The following is a description of a gene set: studied in species Mus musculus Mouse Gene Set: GOBP_REGULATION_OF_LIPID_KINASE_ACTIVITY Any process that modulates the frequency, rate or extent of lipid kinase activity, the catalysis of the transfer of a phosphate group, usually from ATP, to a simple or complex lipid., and this is the list of marker genes: Ins2, Rb1, Rbl1, Nrbf2, Eef1a2, Rbl2, F2 (NCBI Gene Id 14061)